Given this list of marker genes Akirin1, Mstn, Ephb1, Six5, Cav2, here is a description of the gene set: Any process that stops, prevents, or reduces the frequency, rate or extent of skeletal muscle cell proliferation. Mouse Gene Set: GOBP_NEGATIVE_REGULATION_OF_SKELETAL_MUSCLE_CELL_PROLIFERATION species: Mus musculus